The following is a description of a gene set: species: Homo sapiens Reactome Pathway: Neurotransmitter release cycle Neurotransmitter is stored in the synaptic vesicle in the pre-synaptic terminal prior to its release in the synaptic cleft upon depolarization of the pre-synaptic membrane. The release of the neurotransmitter is a multi-step process that is controlled by electrical signals passing through the axons in form of action potential. Neurotransmitters include glutamate, acetylcholine, nor-epinephrine, dopamine and seratonin. Each of the neurotransmitter cycle is independently described. part of: Transmission across Chemical Synapses, and this is the list of marker genes: RIMS1, HSPA8, SYN3, PPFIA3, SLC22A1, SYN1, SLC1A7, SLC5A7, SLC6A13, SYT1, UNC13B, SLC1A3, GLS, SLC6A12, LIN7A, APBA1, PPFIA2, RAB3A, SLC22A2, SLC18A3, CHAT, LIN7C, GLS2, GAD1, SLC1A1, NAAA, VAMP2, SLC17A7, ABAT, DNAJC5, SLC38A2, GAD2, ALDH5A1, PPFIA1 (PTPRF interacting protein alpha 1), SLC1A6, PPFIA4, SLC18A2, ARL6IP5, SNAP25 (synaptosome associated protein 25), SLC6A11, SLC1A2, SYN2, CASK, LIN7B, STXBP1 (NCBI Gene Id 6812), SLC32A1, MAOA, STX1A, TSPOAP1, SLC6A1, CPLX1